The following is a description of a gene set: species: Mus musculus Any apoptotic process in a macrophage, a mononuclear phagocyte present in a variety of tissues. Mouse Gene Set: GOBP_MACROPHAGE_APOPTOTIC_PROCESS, and this is the list of marker genes: Nod2, St6gal1, Sirt1, Ccl5, Ghsr, Plekho2, Pten (phosphatase and tensin homolog), Cdkn2a, Mef2c, Ccr5, Selenos, Gm14461